Given this list of marker genes GRIN2D, GRIK3 (glutamate ionotropic receptor kainate type subunit 3), GRIK1, GRIA2, SHANK1, MEF2C, GRIN2C, GRIN2A, PTK2B, APP (NCBI Gene Id 351), GRID1, CDK5R1, GRIN2B (glutamate ionotropic receptor NMDA type subunit 2B), GRIN1, DLG4, GRIK4, CPEB4, NRXN1, GRIA3, GRID2, GRIA1, GRIN3A, GRIK5, GRIK2, CAPN1, GRIA4, CLN3, NLGN1, C14orf28, ADRB2, GRIN3B, here is a description of the gene set: The series of molecular signals initiated by glutamate binding to a glutamate receptor on the surface of the target cell, followed by the movement of ions through a channel in the receptor complex, and ending with the regulation of a downstream cellular process, e.g. transcription. studied in species Homo sapiens Human Gene Set: GOBP_IONOTROPIC_GLUTAMATE_RECEPTOR_SIGNALING_PATHWAY